The following is a description of a gene set: The process whose specific outcome is the progression of the distal tubule over time, from its formation to the mature structure. In mammals, the distal tubule is a nephron tubule that begins at the macula densa and extends to the connecting tubule. Mouse Gene Set: GOBP_DISTAL_TUBULE_DEVELOPMENT studied in species Mus musculus, and this is the list of marker genes: Pkd1, Tfap2b, Jag1, Pou3f3, Calb1, Notch1, Pax8, Pax2, Klhl3, Pkd2, Wnk4, Umod